The following is a description of a gene set: studied in species Mus musculus This event has been computationally inferred from an event that has been demonstrated in another species.<p>The inference is based on the homology mapping from PANTHER. Briefly, reactions for which all involved PhysicalEntities (in input, output and catalyst) have a mapped orthologue/paralogue (for complexes at least 75% of components must have a mapping) are inferred to the other species. part of: Transcriptional regulation by RUNX1 Reactome Pathway: RUNX1 regulates genes involved in megakaryocyte differentiation and platelet function electronically inferred by orthology from the curated human pathway, and this is the list of marker genes: H3c2, H3f3a, H3c6, H2bc27, H3c4, H2ac19, H4c6, H2ac20, H3c10, H2ac15, H3c13, H4c18, Zfpm1, H2bc7, H2bc1, H2bc15, H3c15, H2ac23, H2bc22, H2ac1, Gata1, H4c9, H2ac10, Kmt2b, H4c3 (H4 clustered histone 3), H4c14, H4c11, H2ac12, H3c7, Sin3a, H2ac7, H4c1, H2ac24, H2bc9, H2bc11, H4c4, H2az2, H2ac4, H2ac13, H2bc12, H4c12, Ash2l, H2ax, H2bc8, H2bc3, H2bc13, Setd1a, H3c11 (NCBI Gene Id 319153), Cbfb (core binding factor beta), H3c8, H3c3, Ep300, H3c1, H4c8, H2ac6, H2ac11 (H2A clustered histone 11), H2ac8 (H2A clustered histone 8), H4c17, H4c2, H2ac22